The following is a description of a gene set: from publication Cui A, Huang T, Li S, Ma A, Pérez JL, Sander C, Keskin DB, Wu CJ, Fraenkel E, Hacohen N (PMID 38057668) Cytokines mediate cell-cell communication in the immune system and represent important therapeutic targets. A myriad of studies have highlighted their central role in immune function, yet we lack a global view of the cellular responses of each immune cell type to each cytokine. To address this gap, the authors created the Immune Dictionary, a compendium of single-cell transcriptomic profiles of more than 17 immune cell types in response to each of 86 cytokines (>1,400 cytokine-cell type combinations) in mouse lymph nodes in vivo. A cytokine-centric view of the dictionary revealed that most cytokines induce highly cell-type-specific responses. For example, the inflammatory cytokine interleukin-1β induces distinct gene programmes in almost every cell type. A cell-type-centric view of the dictionary identified more than 66 cytokine-driven cellular polarization states across immune cell types, including previously uncharacterized states such as an interleukin-18-induced polyfunctional natural killer cell state. species: Mus musculus Mouse Gene Set: CUI_T_CELL_CD4_IL21_RESPONSE_UP Genes positively differentially expressed in cell type: CD4+ T cell upon treatment with cytokine: IL-21 in mouse lymph nodes in vivo., and this is the list of marker genes: Tubb4b, Igfbp4, Psmb5, Socs3, Ly6a, Eif2s2, Eif5a, Prelid1, Ssbp4, Mettl23